The following is a description of a gene set: Human Gene Set: GOBP_REGULATION_OF_NK_T_CELL_ACTIVATION species: Homo sapiens Any process that modulates the frequency, rate or extent of natural killer T cell activation., and this is the list of marker genes: TYK2, IL12A, IL23R (NCBI Gene Id 94006), IL23A, JAK2, IL18, IL12B, ZBTB7B, LGALS3, HSPH1, RASAL3, CD300A